The following is a description of a gene set: electronically inferred by orthology from the curated human pathway studied in species Mus musculus This event has been computationally inferred from an event that has been demonstrated in another species.<p>The inference is based on the homology mapping from PANTHER. Briefly, reactions for which all involved PhysicalEntities (in input, output and catalyst) have a mapped orthologue/paralogue (for complexes at least 75% of components must have a mapping) are inferred to the other species. Reactome Pathway: Regulation of gap junction activity part of: Gap junction trafficking and regulation, and this is the list of marker genes: Gja1